Given this list of marker genes Adarb2, Zbp1, Adad2, Adar, Adad1, Adarb1, here is a description of the gene set: species: Mus musculus Mouse Gene Set: GOMF_DOUBLE_STRANDED_RNA_ADENOSINE_DEAMINASE_ACTIVITY Catalysis of the reaction: adenosine + H2O = inosine + NH3, in a double-stranded RNA molecule.